The following is a description of a gene set: studied in species Homo sapiens Pathway Definition from KEGG: GH -> GHR -> JAK2 -> STAT5 => IGF1 Human Gene Set: KEGG_MEDICUS_REFERENCE_GH_JAK_STAT_SIGNALING_PATHWAY GH-Jak-STAT signaling pathway. Pathway ID: N00907. Pathway type: Reference. Pathway class: nt06324 GHRH-GH-IGF signaling., and this is the list of marker genes: STAT5B, GH2, GH1, IGF1, STAT5A, JAK2, GHR